Given this list of marker genes SOST, TCIRG1, PLEKHM1, CLCN7, SLC4A2, here is a description of the gene set: Sclerosis (abnormal hardening) of cortical bone, characterized by increased radiodensity. Cortical sclerosis Human Gene Set: HP_CORTICAL_SCLEROSIS species: Homo sapiens